Given this list of marker genes PDGFRA, BMP4, MEF2C, PDGFRB, KIRREL3, MTSS1, NOTCH2, TCF21, NOTCH3, here is a description of the gene set: Human Gene Set: GOBP_GLOMERULUS_MORPHOGENESIS The process in which the anatomical structures of the glomerulus are generated and organized. The glomerulus is a capillary tuft surrounded by Bowman's capsule in nephrons of the vertebrate kidney. species: Homo sapiens